Given this list of marker genes Lyn, C1qc, Ctss, Lgals3, Irf8, Cx3cr1, Csf1r, Tlr1, P2ry12, C1qa, Hck, Tmem119, Cd33, C1qb, Ms4a6d, Itgam, Mpeg1, Fcrl2, Ptprc, Adgre1, Aif1, Ms4a6b, F13a1, Trem2, Tyrobp, Cd68, here is a description of the gene set: from publication Bedogni F, Hevner RF (PMID 34321999) studied in species Mus musculus Mouse Gene Set: HEVNER_TELENCEPHALON_MICROGLIA Genes selectively expressed by brain microglia in embryonic day 14.5 mouse telencephalon.